Given this list of marker genes UCHL3, EIF2B2, PSPC1, EMG1, RGS16, CRELD2, BAZ2B, RPL36AL, MAP3K7CL (MAP3K7 C-terminal like), UBXN1, BCL2L13 (BCL2 like 13), DNAJC15 (NCBI Gene Id 29103), FDPS, RMND1, PHF7, CD59, NASP, RASGRP3, RBMX, IPO7, REEP5, PLXNB2, KIFAP3, EMC2, TDRD7, GDPD5, UBA6, RHOQ, PMS2P2, MRPS2, NRGN (NCBI Gene Id 4900), EMC9 (ER membrane protein complex subunit 9), GSTK1 (glutathione S-transferase kappa 1), MDH1, PRKCD, MARCHF5, CCND3, PSMD8, ASH2L, TUT7, KIF2C, SEPTIN2, ZHX2, TEX30, PREB, TST, HSD17B12, CLIP2, DCTPP1, MGAT1, REXO2, RBM4, PSMD4, CFAP298, FAM216A, PTPN9, ZNF85, IDH2, RAB33A, CENPI (NCBI Gene Id 2491), CSTB, PRCC, DTYMK, JPT2, COMMD4, TADA3, ECI1, DAZAP1, ANKRD26, GCDH, ATP5F1B, PGM1, TIAM1, MTREX, KIFC1, LINC00342, PDCD10, ITPR2, ORC3, H2BC9, NECAP2, CYC1, PSMC1, P4HA2, TXN2, MAP4K1, DNAJC8, NAPG, ELAVL1, KCNMB3, ALDOA, GTF2E2, SPTAN1, ARF3, DTWD1, OSBPL2, CNOT8, DEPDC5, PIN1, NDUFAF7, MFHAS1, SMIM7 (NCBI Gene Id 79086), RHOG, CMC4, FBXO38, DDX56, CDK19, PDK3 (NCBI Gene Id 5165), EIF3F, PSMB10, TBCB, WDR77, CCT7, CSE1L, RTF2, ELAC2, PSMA7, YIPF1, TUBA1C (NCBI Gene Id 84790), BCL2L2, PPIH, POLR2B, AGPS, RWDD1, ZNF254, CD3D, PARP2, GTF2E1, NFYB, PIGV, DAP, CNIH1, HIKESHI, ICMT, LAGE3, CMAS, TPI1, INTS14, SNX5, MAPK12 (NCBI Gene Id 6300), SERBP1, MEN1, ZNF280D, RAD17, PSMA2, POGZ, ELF4, BCAS4, PSMB5, DDX23, RMND5B, GMDS, RBM42, HPS5, MTERF3, TMEM11, MNS1, UBAP2, RUVBL1, UGP2, TMEM186, PSPH, CEP350, POLDIP3, SART1 (spliceosome associated factor 1, recruiter of U4/U6.U5 tri-snRNP), H1-2, PPP2R5C, PDHX, ZBTB14, ARL2BP, UBR4, CLCN3, HNRNPM, GMPR2, LAMTOR2, ELK3, CRIP1, FAM50B, PLEK, ATIC, EXO1, COPS5, MTHFD1, TPCN1, HERC4, TRRAP, MRPL16, SWAP70, TMEM165, DNAJB6, TOP1, POGK, DENND4A (NCBI Gene Id 10260), ZNHIT1, ANP32A, CDK7, SKA1, URM1, UBE3C, PPAT, here is a description of the gene set: Human Gene Set: GSE12845_NAIVE_VS_DARKZONE_GC_TONSIL_BCELL_DN Genes down-regulated in comparison of naive B cell versus dark zone germinal center B cells. B cells from human tonsil and blood were sorted using flow cytometry. The human samples were processed immediately ex-vivo using markers for known B cell subsets. species: Homo sapiens from publication Longo NS, Lugar PL, Yavuz S, Zhang W, Krijger PH, Russ DE, Jima DD, Dave SS, Grammer AC, Lipsky PE (PMID 19023113)